Given this list of marker genes CHCHD10, TBK1, VCP, SQSTM1, PIGA, PC (pyruvate carboxylase), TARDBP, FUS, here is a description of the gene set: species: Homo sapiens Human Gene Set: HP_NEURONAL_LOSS_IN_THE_CEREBRAL_CORTEX Neuronal loss in the cerebral cortex